The following is a description of a gene set: High confident estrogen up-regulated genes exclusively in MCF7 cells merged from 74 NGS datasets-based comparisons (10% topmost up-regulated genes and consistent in at least 50% comparisons). As one of the most successful cancer therapeutic targets, estrogen receptor-alpha (ER/ESR1) has been extensively studied over the past few decades. Sequencing technological advances have enabled genome-wide analysis of ER action. However, comparison of individual studies is limited by different experimental designs, and few meta-analyses are available. Here, by ingesting large amount of E2-related transcriptomic data sets in breast cancer cell lines, we identified gene expression changes across 66 RNA-seq and 80 microarray experiments based upon the E2-induced fold change in gene expression. MCF7 and T47D cell lines have been used extensively as ER+ breast cancer models. However, extrapolation of this data to breast cancer is complicated by the known heterogeneity of breast cancer and potential biases arising from cell line-specific results. Importantly, while EstroGene contains transcriptomic data from 19 different breast cancer cell lines, data from MCF7 and T47D account for ~50% and ~20%, respectively, of all experiments. To characterize and describe contextual cell-line specific responses, we identified the top 10th percentile of upregulated and downregulated genes in an individual study and consistent among 50% of comparisons within MCF7 or T47D experiments. For non-MCF7/T47D experiments we lowered the threshold to 40% across studies due to the larger heterogeneity in this subset. Intersection of the three subsets yielded 89 and 96 uniquely regulated genes in MCF7 and T47D, we also identified genes that were not regulated in MCF7 and T47D but showed E2-induction in some other cell lines. from publication Li Z, Li T, Yates ME, Wu Y, Ferber A, Chen L, Brown DD, Carroll JS, Sikora MJ, Tseng GC, Oesterreich S, Lee AV (PMID 37272757) studied in species Homo sapiens Human Gene Set: LI_ESTROGENE_MCF7_E2_RESPONSE_UP, and this is the list of marker genes: RBP7, PLAT, NPY5R, NR5A2, CT62, PLIN5, CELSR2, FOS, FCMR, ANKRD2, SCNN1B, TIFA, PADI3, UGT2B15, RAB31, NAV2, COL12A1, CHST8, TIAM1, ADRB1, MAT1A, SERPINA1, SEMA3B, SLC22A5, CXXC5, CALCR, PIM1, SDK2, SLITRK4, TMEM164, FRK, SYTL4, MSMB, LRIG1, KCNK6, HCK, SYBU, COL21A1, SERPINA5, NXNL2, CYP26B1, PLAC1, LONRF2, C1QTNF6, DDX10, SOX3, TIPARP, MGP, SGK1, RHOBTB1, JAK2